Given this list of marker genes DNM1, ARMC3, PRKCD (NCBI Gene Id 5580), TNFRSF21, GNA15, WDSUB1, ACTR1B, POLR3E, CD36, MCRIP2, ITGB7, RGCC, IER3, PER1, SLC7A5, FBP1, CIB1, TEX264, TIPARP, CLCN5, UBTD1, SAMD4B, MRGBP, USP6NL, HM13, ERO1A, TMEM80, G6PC3, KCNK6, RRP8 (NCBI Gene Id 23378), OGFOD3, TCEA1 (NCBI Gene Id 7865), ANKRD34A, TRAPPC6B, TBRG1, PTP4A2, PPP3R1, GRPEL1, LARS1, NIN, TTC27, ARHGAP12, CNNM2, CRTAP, ABCC5, CAMSAP1, IL9R, OSGIN2, ROPN1, EEF1A2, MIR99AHG, ATF4, CHP1, LIMD1, FARSB, CLIC4, SEPTIN9, LHFPL4, FAM220A, PEAK1, NOC2L (NOC2 like nucleolar associated transcriptional repressor), IDO1, LIMK1, VOPP1, SLC7A1, HSF1, TMED4, BFAR, PHOSPHO1, CNIH1, MARK3, NFKB2, PSMA3, UBE2M, ALG5, TENM4, TLN1 (NCBI Gene Id 7094), SLC50A1, NCSTN (NCBI Gene Id 57297), MINK1, GPATCH2, PIGX, ETFA, PPP2R2A, CCNO, HSPA12A, PFDN2, LARP4B, ARIH1, COMTD1, RUNX2, TTC17, MPV17L2, GATC, PSPH, RGS1, AUH, PHKA2, HEBP1, LEO1, FAM43A, NT5DC3, TSR1, HESX1, TEP1, UTP4, ERP44, ACAP1, SOAT2, LRRC4, LAP3, MAEA, YBX3, GATA2, RPL34, PHGDH, KRTCAP3, AKIRIN2, ASB4, RHOB (NCBI Gene Id 388), ELOVL5, OSGEP, SAMD11, KRT222, SNHG12, MSANTD3, DUSP1, POLR1C, PTPN3, GTPBP2, SIPA1L1, ATP6V1B2, DGKG, DDRGK1, WDR74, ZBTB7C, POLD4, IRAG2, SHISA2, YAE1, RSL1D1, SYDE2, METRNL, ENDOG, ARL6IP5, SLC25A32, PHYHD1, FNDC10, TNFAIP3, RPL27, HRH2, HAX1, MRPS22, PTPN2, ERP29, CR1L, STAB2, NFKBIB, IL4I1, NAA35 (N-alpha-acetyltransferase 35, NatC auxiliary subunit), KCNJ3, KLHL22, NFE2L1, RPL7L1, ZNF131 (NCBI Gene Id 7690), OLFM1, MID2, ZCCHC2, TMEM165, ZNF706, WDR43 (NCBI Gene Id 23160), SOCS2, DUSP5, CD40, EXO5, CCR1, HILPDA, HSPA1B, NES, KLF10 (KLF transcription factor 10), CSNK1A1, MRPL17, FYN, ATP6V0A1, EMC7, HMG20B, NCF4, RNF222, TMEM30B, PCNP, ESD, GSDMD, CASP6, ISCU, RETSAT, NIBAN2, NPAS4 (neuronal PAS domain protein 4), ALDH18A1, FBXO8, THRA, here is a description of the gene set: Human Gene Set: GSE5589_WT_VS_IL10_KO_LPS_AND_IL10_STIM_MACROPHAGE_45MIN_DN IL-10 or IL-6 stimulation of control 129xC57BL/6 murine bone marrow derived macrophages in the presence of LPS. We used microarrays to detail the global programme of gene expression changes in response to IL-6 or IL-10 stimulation in the presence of lipopolysaccharide. BMDMs were isolated from control, IL-6-/-, and IL-10-/- mice on a 129XBL/6 mixed background mice and differentiated in the presence of CSF-1 for 6-7 days. Cells were scraped and plated in 6 well plates at 2x10e6/well. Cells were washed with complete DMEM and rested for 1-2 hr before stimulation with combinations of IL-10 (10 ng/ml), IL-6 (2 ng/ml) or LPS (100 ng/ml) for 45 min or 180 mins. Complete biological replicates were performed. from publication El Kasmi KC, Holst J, Coffre M, Mielke L, de Pauw A, Lhocine N, Smith AM, Rutschman R, Kaushal D, Shen Y, Suda T, Donnelly RP, Myers MG Jr, Alexander W, Vignali DA, Watowich SS, Ernst M, Hilton DJ, Murray PJ (PMID 17114459) species: Homo sapiens Genes down-regulated in bone marrow-derived macrophages at 45 min of stimulation by IL10 and LPS: wildtype versus IL10 knockout.